Given this list of marker genes CORO1A, ARHGAP25, RAC2, GIT2, ACAP2, HLA-G, CRLF3, PTPRC, LYN, ANXA11, SP110, HLA-B, CD53, HLA-F, ARHGDIB, TXNIP, WAS, TAPBP, GMIP, EMP3, CYBC1, FMNL1, SIPA1, HLA-C, CYRIB, LIMD2, CORO7, B2M, RIPOR2, GRK6, GPSM3, HCLS1, ARPC3, SELL, HLA-E (major histocompatibility complex, class I, E), ICAM3, LRRFIP1, DPEP2, CD48, LAPTM5, PTPN6, EVI2B, HLA-A, LRCH4, FXYD5, STAT6, LSP1, here is a description of the gene set: studied in species Homo sapiens Human Gene Set: GNF2_PTPN6 Neighborhood of PTPN6 Neighborhood of PTPN6 protein tyrosine phosphatase, non-receptor type 6 in the GNF2 expression compendium